Given this list of marker genes SLC39A6, MIR187 (microRNA 187), ENSG00000263765 (NCBI Gene Id 105372058), TRAPPC8, GALNT1, ENSG00000266988, MLECP1, RPS27P28, SLC14A2, RN7SKP182, RPL12P40, ENSG00000303986, MIR924HG, LINC01902, ENSG00000295284, KLHL14, ENSG00000285940, SETBP1, ENSG00000267202, ENSG00000285095, ASXL3-DT, HNRNPA1P7, ZNF396, CELF4, RNA5SP455 (RNA, 5S ribosomal pseudogene 455), RNA5SP454, DSG2, DSC1, KRT8P5, MIR3975, MIR4318, ARIH2P1, CDH2, LRRC37A7P, RPRD1A, MIR302F, RNF125, RNU6-857P, KC6, ELP2, NOL4, RNU6-167P, ENSG00000287803, ENSG00000286559, ASXL3, ZNF397, MIR4319, RPL7AP66, GAREM1, DSG3, RNF138, ZNF24, DSG4, DTNA, ZSCAN30, RPL7AP67, DSG1-AS1, ENSG00000283458, LINC02879, SLC25A52 (NCBI Gene Id 147407), MEP1B, RPL17P45, LINC01901, ENSG00000267039, SIGLEC15, NPM1P1, PIK3C3 (phosphatidylinositol 3-kinase catalytic subunit type 3), CLUHP6, KIAA1328, B4GALT6, SLC14A2-AS1, RNA5SP453, RNU6-1050P, DSC3, SETBP1-DT, MIR5583-1, RIT2, MAPRE2, ENSG00000286426, DSG2-AS1, TPGS2, ENSG00000304612, INO80C, CCDC178 (NCBI Gene Id 374864), RNU6-408P, PGDP1, LINC00907, DSG1, MIR924, MIR5583-2, LINC01478, NRBF2P1, TTR, SLC14A1, MIR3929, ZNF271P, RNU6-1242P, ENSG00000278464, DSC2, WBP11P1, RNU6-706P, DSCAS, LINC01477, COSMOC, MOCOS, SYT4, C18orf21, ZNF24TR, ENSG00000297765, RN7SKP44, FHOD3, here is a description of the gene set: Human Gene Set: chr18q12 species: Homo sapiens